Given this list of marker genes TBX21, MLH1, ATAD5 (NCBI Gene Id 79915), CD40, PAXIP1, PTPRC, IL4, PMS2, CD28, MSH2, IL2, here is a description of the gene set: Any process that activates or increases the frequency, rate or extent of isotype switching to IgG isotypes. studied in species Homo sapiens Human Gene Set: GOBP_POSITIVE_REGULATION_OF_ISOTYPE_SWITCHING_TO_IGG_ISOTYPES